Given this list of marker genes ATP5MC3, CALB1, UQCRFS1, COL1A1, CA4, COL3A1, ACSS2 (acyl-CoA synthetase short chain family member 2), UQCRQ, COL4A5, FABP3, GHITM, NDUFB11, CX3CL1, TFRC, NREP, DIABLO, here is a description of the gene set: from publication de Magalhães JP, Curado J, Church GM (PMID 19189975) Genes consistently underexpressed with age, based on meta-analysis of microarray data. Human Gene Set: DEMAGALHAES_AGING_DN MOTIVATION: Numerous microarray studies of aging have been conducted, yet given the noisy nature of gene expression changes with age, elucidating the transcriptional features of aging and how these relate to physiological, biochemical and pathological changes remains a critical problem. RESULTS: We performed a meta-analysis of age-related gene expression profiles using 27 datasets from mice, rats and humans. Our results reveal several common signatures of aging, including genes consistently overexpressed with age, the most significant of which was APOD, and genes underexpressed with age. We characterized the biological processes associated with these signatures and found that age-related gene expression changes most notably involve an overexpression of inflammation and immune response genes and of genes associated with the lysosome. An underexpression of collagen genes and of genes associated with energy metabolism, particularly mitochondrial genes, as well as alterations in the expression of genes related to apoptosis, cell cycle and cellular senescence biomarkers, were also observed. By employing a new method that emphasizes sensitivity, our work further reveals previously unknown transcriptional changes with age in many genes, processes and functions. We suggest these molecular signatures reflect a combination of degenerative processes but also transcriptional responses to the process of aging. Overall, our results help to understand how transcriptional changes relate to the process of aging and could serve as targets for future studies. AVAILABILITY: http://genomics.senescence.info/uarrays/signatures.html. SUPPLEMENTARY INFORMATION: Supplementary data are available at Bioinformatics online. species: Homo sapiens